The following is a description of a gene set: studied in species Mus musculus Cytokines mediate cell-cell communication in the immune system and represent important therapeutic targets. A myriad of studies have highlighted their central role in immune function, yet we lack a global view of the cellular responses of each immune cell type to each cytokine. To address this gap, the authors created the Immune Dictionary, a compendium of single-cell transcriptomic profiles of more than 17 immune cell types in response to each of 86 cytokines (>1,400 cytokine-cell type combinations) in mouse lymph nodes in vivo. A cytokine-centric view of the dictionary revealed that most cytokines induce highly cell-type-specific responses. For example, the inflammatory cytokine interleukin-1β induces distinct gene programmes in almost every cell type. A cell-type-centric view of the dictionary identified more than 66 cytokine-driven cellular polarization states across immune cell types, including previously uncharacterized states such as an interleukin-18-induced polyfunctional natural killer cell state. Mouse Gene Set: CUI_MACROPHAGE_IL15_RESPONSE_DN from publication Cui A, Huang T, Li S, Ma A, Pérez JL, Sander C, Keskin DB, Wu CJ, Fraenkel E, Hacohen N (PMID 38057668) Genes negatively differentially expressed in cell type: Macrophage upon treatment with cytokine: IL-15 in mouse lymph nodes in vivo., and this is the list of marker genes: Ppia, Ftl1, Tns1, Crip1, Ubald1 (UBA-like domain containing 1), Rxra, Atp5pd, Aldoa, Sec61b, Atp5mc2, Cox4i1, Tcf3, Abcg3, Ppfia4, Syndig1l, Pts, Prxl2b, Uqcr11, Tmsb10, Gapdh, Ubb, Mapk14, Eef1a1, Cox7a2l, Rxrg, Calm2, Helz (helicase with zinc finger domain), Cox8a, Tep1, Vamp5, Gdi2, Comt, Abhd17a, Ptp4a3, Gnpda1 (NCBI Gene Id 26384), Cox5a, Rgs10, Mtss1